The following is a description of a gene set: species: Mus musculus part of: Metabolism of proteins electronically inferred by orthology from the curated human pathway Reactome Pathway: Post-translational protein modification This event has been computationally inferred from an event that has been demonstrated in another species.<p>The inference is based on the homology mapping from PANTHER. Briefly, reactions for which all involved PhysicalEntities (in input, output and catalyst) have a mapped orthologue/paralogue (for complexes at least 75% of components must have a mapping) are inferred to the other species., and this is the list of marker genes: Il33, H2ac24, Brca1, Kdm8, St8sia5, Brcc3, Snx3, Rab7, Fn3krp, Cga, Rab1b, Wfs1, Rnf146, Eef1akmt1, Usp3, Sin3a, Muc20, Man1c1, Dtl, Renbp (NCBI Gene Id 19703), Thbs2, Taf10, Vdac2, Glt28d2, Nrn1, Muc5b, Rab36, Nop58, Aurkb, Usp17lb (ubiquitin specific peptidase 17-like B), Alpi, Mgat1, Psmb11, Spaca4, Senp2, Hdac7, Alg6, Vdac3, Stam, Galnt12, Cfp, Ly6d, Pros1, Sema5b, Nup42, Jmjd4, Tmed10, Asgr1, Foxl2 (forkhead box L2), Zfp131, Kdelr1, St3gal2, St6galnac1, Kctd7, Fstl3, Ankrd9, St3gal4, Nup85, Amdhd2, H2ac20, Cmas (cytidine monophospho-N-acetylneuraminic acid synthetase), Aaas, Myc, Stag1, Hnrnpk, Taf9b, Tubal3, Amfr, Lipt2, H4c6, Usp42, Eid3, H2ac11, Usp29, H4c18, Galnt15, Rab4a, Kbtbd8, H2ac4, Hif3a, Trp53, Mdc1, Eef2, Adamtsl4, Copb2, Cst3, Nup133, Nup155, Cnih2, Ptrh2, Kbtbd13, Nanp, Gmppa, Chrdl1, Smad1, Vcpip1 (NCBI Gene Id 70675), Proz, Trim27, H4c17, Eef1a1, Fbxl8, Adamts1, Sec31b, Tnks2, Usp37, Rnf152 (ring finger protein 152), Igfbp3, Ckap4, Apoa2, Areg, Lypd4, Fbxl19, Rnf123, Fbxl3, H2bc11 (H2B clustered histone 11), H4c1, Hic1, Cul1, Mxra8, Cntn3, H4c14, Pigv, Leo1, Nsmce4a, Rnf7, Ttll7, Prkdc, Rab39b, Ufd1, Psmb9, Usp5, Tab1, Arsi, Tuba4a, Rps23 (NCBI Gene Id 66475), Prmt3, Otoa, H2ac23, Cog8, Mdga1, Nagk, Ins2, H2ac10, Trappc9, B4galnt2, Jmjd7, Muc17, Pigs (NCBI Gene Id 276846), Kdelr2, Nlrp3, Igfbp7, Rab11a, Notum, Pex5, Tuba1a, Nfrkb, Cbx8, Usp17lc, Rab44, Copg1, Tnc, H4c3, Rab19, Asxl1, Nr3c1, Alg1, H2bc12, Gcnt3, Apob, Dcun1d5, Galntl5, Fbxo31, Lrr1, Socs3, Galnt4, Smc3, Cog7, Lypd5, Galnt1, H4c2, H2bc22, Ly6g6c (NCBI Gene Id 68468), Manea, St8sia4, Dctn6, Psmb8, Psmd1, Vdr, Etfbkmt, Psme2, Kng2, Uso1, Galnt9, Rnf168, Ccdc22, Nsf, Ep300, Nedd8, Rad52, Fem1b, Rab39, Cbx2, Gp2, Seh1l, U2af2, Psma6, Ulbp1, Dnmt3b, Mdga2, Psca, Bglap2, Arrb2, Asb18, Apol10a, Fbxw4, Ino80c, Asb12, Alg8, Tnip1, Gnpnat1, Npm1, Sumf2, Apol8, Rab5c, Dph2, Nans (N-acetylneuraminic acid synthase (sialic acid synthase)), Sumf1, Sec24a, Fbxl21, Pigt, Ino80b, Fbxl15, Rpl27a, Fbxo27, Asb11, Adamts4, Psmb7, Arf1, Prkcsh, Galnt14, Psma5, Usp28, Pomt1, Thsd4, Amelx, Ube2k, Spp2, Rwdd2b, Fbxo17, Nr1h4, Fbxo32, Scmh1, A4gnt, Rab1a, Tnfaip3, Rraga, Traf3, Fut10, Pomp, Axin2, Neu3, Ube2n, Rab40b, Rae1, Spp1, Fbxl14, Tuba8, Psmc3, Babam1, Sptbn4, C1galt1, Gpihbp1, Mta1, Alg12 (NCBI Gene Id 223774), Rab30, Rccd1, Ktn1 (NCBI Gene Id 16709), Dph6, B4galt6, Fbxo9, St6gal2, Ctsc, H2bc13, Rbbp7, H4c9 (NCBI Gene Id 319158), Rab10, Tdg, Apol11b, Ubd, Dynll1, Apol7b, Gpc3, Cd52, Esr1, Copb1, St6galnac4, Psme3 (proteaseome (prosome, macropain) activator subunit 3 (PA28 gamma, Ki)), Psmc5 (NCBI Gene Id 19184), Psmc4, Chst4, Dcun1d1, Afp, Sparcl1, Psmd12, Rab8a, Copg2, Scg3, Bet1, Hif1a, Cd109, Trappc5, Negr1, Apoe, Apoa1, Mitf, Lypd2, Apoa5, B3gnt8, H2ac8, Cd55, Nudt14, Rnf128, Camkmt, St6galnac3, Prkn, Sec24d, Fstl1, Scfd1, Lman2l, Rabggta, Rab3a, F8, Dctn1, Rab21, Pcna, Rab8b, Ano8, H4c4, Socs2, Muc13, Hrc, Daxx, Reck, Lypd8, Fkbp8, Asb5, Mrtfa, Hcfc1, Adamtsl2, Arcn1 (NCBI Gene Id 213827), Pomt2, Ube2r2, Vhl (NCBI Gene Id 22346), Ubb, Timp1 (NCBI Gene Id 21857), Dlat, Smad7, Otub1 (OTU domain, ubiquitin aldehyde binding 1), Ddb1, Rab32, St6galnac6, Dcaf4, Rela, Ctr9, Cdh2, Neu4, Ccna1, Psg22, Chst8, Gas6, Ccnf, Wdr48, Ttll3, Arsa, H2bc3, Alb, Cnih3, Fktn, Thy1, Asxl2, Usp17ld, Usp17la, Psma1, Arfgap2, Rab34, Psmb10, Plet1, Psmb5, Foxk1, Pcgf2, B3gnt9, Lman1, Pigf, Asgr2, Spsb3, Satb2, Npl (N-acetylneuraminate pyruvate lyase), Fam20a, Enam, Golga2, Vnn1, St3gal3, Rabggtb, Fbxl16, F7, Ifih1, Pomk, Asb16, Nrn1l, St6galnac2, Foxo4, Matn3, Sprn, Pigg (NCBI Gene Id 433931), Rad21, Tmed3, Prss23, P4hb, Hdac4, Psmd13, Men1, Sbspon, Ube2s, Kdelr3, Commd1, Cul4a, L3mbtl2, Col7a1, Slc35a4, Aplp2, H2bc15, Ly6h, Nsmce3, Rab27b, Psmb4, Rcn1, Engase, Rara, Pex13, Tuba1c, Axin1, B3galnt2, Folr2, Psmg1, Usp47, Ceacam1, Neu2, Cbx4 (chromobox 4), Nfkbia, Suds3, Wsb1, Gfus, Psma7, Park7, Apol7a, Gorasp1, Dhps, Rab6a, H2bc8, H2bc1, Ttll9, Apol9b, Btbd6, Ttll12, Josd2, Rpa1, H2ac7, Apol9a, Cdk1, Pigp, Senp8, Tmem132a, Ndc1, Mul1, Ins1, Fuom, Eef2kmt, Dlst, Commd5, H2bc9, Commd7, Dnajc24, Nr5a1, Cish, Btbd1, Psmc6, Fem1a, Tubb2b, Tmed9, Pias4 (protein inhibitor of activated STAT 4), C3, Rab35, Cul4b, Folr1, Fbxl4, Ly6k, Cyld, Fgg, Asb14, Klhl41, Cdc34, F9, Rps6, Ar, Pigyl, Pigw, Psmb6, F10, Lgals1, Sec24b, Dync1li2, Rigi, Tgfa, Ube2e3, Fbxo40, Adamts13, Tnip3, Nup205, Actr1a, Scg2, Commd10, Dnmt1, B3gnt6, Sec16b, H2ac12, Fbxw9, Gan, Rps27a, Ring1, Tubb4a, Actr10, Hsp90b1, Eef1akmt2, Rab38, Klhl5, Calm1, St3gal5, Bmp4, Ube2w (NCBI Gene Id 66799), Adamts18, Yy1, H2ac6, Calr, Ank1, Penk (preproenkephalin), Rab18, Tubb6, Rab3b, Prss41, Josd1, Nup210, Sptbn2, Rab37, Fbxl13, Asb8, Drg2, Trf, Pigb, Fgf23 (NCBI Gene Id 64654), H4c12, Blm, Gfpt2, Epas1, Alpl, Spon1, Ttll2, Nup93, Pigx, Vcp, Phc1, Usp26, Vdac1, Arsj, Dcaf13, Fbxl7 (F-box and leucine-rich repeat protein 7), Adamtsl1, Otud7a, Sec31a, Lman1l, Ppp6c, Psmd6, Thrb, Fkrp, Kctd6, Vgf, Pofut2, Emid1, Ggcx, Usp21, St8sia2, Lypd3, Vcpkmt, Fut11 (fucosyltransferase 11), Lmo7, Arf5, Riox1, Otud3, H2ac22, Slc35c1, Ing2, Usp19, Mbd1, Fpgt, Becn1, Wdr20, H2ac25, Smc6, Rps2, Apol10b, Bard1, C4b, Nfkb2, Nup58, Psg29, B3gnt3, Rab26, Serpind1, Asb10, Psmc1, Adamtsl5, Nsmce2, Ube2e1 (ubiquitin-conjugating enzyme E2E 1), Gmppb, Ptp4a2, Tuba3b, Tectb, H2ac15, Klhl13, Rtn4rl2, Wsb2, Pigz, Adamts15, Nr1i2, Crppa, Spsb2, Kdm1b, Cpm, Derl1, Ahsg (alpha-2-HS-glycoprotein), Il6, Ube2g1, Psmd7, Amtn, Mgat5b, Tubb4b, Apol7e, Asb17, H2bc7, H2ac13 (NCBI Gene Id 319191), Ube2c, Proc, Trp53bp1, Rab40c, Neu1, Asb9, Uchl3, Msln, H2ac1, Bmi1, Top2a, Rab33a, Rnf40, B3gntl1, Tuba1b, Nsmce1, Nup54, H4c11, Mepe, Birc3, Fut8, Psmg4 (NCBI Gene Id 69666), Fbxo30, Muc1, Usp4, Psma4, Klhl11 (kelch-like 11), Piga, Commd4, Fbxl5, Ly6e, H4c8, Meltf, Fbxo10, Tomm20, Serpina10, Dolk, Ncoa1, Dcaf10, Sts, Dcaf6, F2, H2ac19, Mgat4c, Psme1, St8sia3, Mmrn1, Mysm1, Man2a1, Mfge8, Usp12, Plaur, Ube2d1, Tfpt, Rab9b (NCBI Gene Id 319642), Smurf2, Usp25, Man1a, Chgb, Muc15 (NCBI Gene Id 269328), Psma2, Uba1, Usp44, Smad3, Adamts12, Gcnt7, Dcaf5, Pigl, Ceacam2, Sumo1, Gata3, Pex12, Psma3, Xpc, Psmd4, Fdx1, Cops6, Psmc2, Arsg (arylsulfatase G), Usp22, Dag1